The following is a description of a gene set: Human Gene Set: ZNF777_TARGET_GENES studied in species Homo sapiens from publication Yevshin I, Sharipov R, Kolmykov S, Kondrakhin Y, Kolpakov F (PMID 30445619) Genes containing one or more binding sites for (ZNF777) in their promoter regions (TSS -1000,+100 bp) as identified by GTRD version 20.06 ChIP-seq harmonization., and this is the list of marker genes: SLC27A6, RASL10A, CCNJL, MRPL39, ENSG00000260136, LRRC63, MICAL1, RPS29, GALNT4, FXYD5, INTS12, FAM133B, MCCC1, APPBP2-DT, GNAL (NCBI Gene Id 2774), THOC1-DT, GAPDH (NCBI Gene Id 2597), CERS4, LINC01023, STAT6, LRWD1, MEGF10, SPACA9, APPBP2, RTTN, LDHA, MATN1-AS1, POLG, RANBP9, HAGLR, ZNF497-AS1, FNDC1-AS1, MTBP, MVB12A, SNX10-AS1, FRA10AC1, GNAO1-DT, CASKIN2, KIRREL1, GSTCD, CCNB2, TSEN54, UBE2I, THOC1, CUX1, SLC44A1, LIMD1, ANKRD34B, LCP1, KDM5A, ZNF396, CCDC77, MBTPS2, RNFT1-DT, HELB, POLG-DT, CNR1, POC1B, HOXD1, LINC02901, RNF130, LSG1, RAB37, GAPDH-DT, RBM24, UNKL (NCBI Gene Id 65259), MRPL13, GNAO1 (G protein subunit alpha o1), LRR1, ANKRD27